The following is a description of a gene set: Genes up-regulated in mammary glands from the CITED1 knockout mice: homozygotic vs wild type (WT) animals. Mouse Gene Set: HOWLIN_CITED1_TARGETS_2_UP species: Mus musculus Expression microarray analysis identified CITED1 among a group of genes specifically upregulated in the pubertal mouse mammary gland. At puberty, CITED1 localizes to the luminal epithelial cell population of the mammary ducts and the body cells of the terminal end buds. Generation of CITED1 gene knockout mice showed that homozygous null mutants exhibit retarded mammary ductal growth at puberty and, in addition, dilated ductal structures with a lack of spatial restriction of the subtending branches. Analysis of CITED1 homozygous null and heterozygous null mammary gland gene expression using microarrays suggested that the mammary-specific phenotype seen in the homozygous null females is due to a disturbance in the transcription of a number of key mediators of pubertal ductal morphogenesis. These include estrogen and TGFbeta responsive genes, such as the EGFR/ErbB2 ligand, amphiregulin, whose transcription we suggest is directly or indirectly regulated by CITED1. from publication Howlin J, McBryan J, Napoletano S, Lambe T, McArdle E, Shioda T, Martin F (PMID 16278680), and this is the list of marker genes: Sgcg, Malat1, Trim27, Ucp1, Wnt5a, Gbp2b, Cd24a, Dynlt1b, Iqgap1, Sprr1a, Map3k7, Resf1, Ifi44, Kif18a, Fbxo32, Nfia, Smarca4, Xist, Lactb2, Myb